Given this list of marker genes Rap1gap, Tap2, Arid5b, Ogfr, Glipr2, Tcf7l2, Mvp, Ube2l6, Bcl2a1d, Ly6e, Psmd3, Eif1, Lap3, Vasp, Ggct, Vps29, Lyar, Mtss1, Dnaja2, Psme2, Tmem38b, Xaf1, Odc1, Cldnd1, Spi1, Rpf2, Mcur1, Hprt1, Fgl2, Tle3, Noc4l, Tbcb, Mrpl21, Sdad1, Lcp2, Srp19, Il10ra, Zbp1, Zfp318, Cd274, Serpina3f, Psma7, Tapbpl, Txndc17, Itgae, Lrrc59, Mat2a, Hhex, Srsf3, Gbp4, Polr2i, Pdha1, Wdr43, Bcl2l14, Marchf5, Ube2l3, Gbp7, Bbx, Snrnp40, Ccl17, Anxa4, Ube2n, Edem1, Ifi207, Sp110, Mdfic, Zyx, Psmb10, Cacnb2, Vdac2, Ly6a, Cnp, Gpr33, Hnrnpab, Irf5, Sting1, Eloc, Rmdn3, Isg15, Lgals3bp, Trafd1, Farsa, Larp1b, Samhd1, Socs2, Pals2, Irgm2, Ikzf2, Laptm4b, Lsm1, Prkd3, Slco3a1, Irf1, Reep3, H2-DMb2, Peli1, Ifi204, Igtp (NCBI Gene Id 16145), Ssr2, Eif6, Calhm6 (calcium homeostasis modulator family member 6), Lims1, Ifi47, Riok3, Nop58, Nufip1, Ccnd2, Cops5, Prdx1, Ndufab1, Procr, Chd7 (chromodomain helicase DNA binding protein 7), Cyrib, Plek, Ppa1, Acer3, Rexo2, Larp1, Ccl22, Ezr, Gbp5, Nmi, Pnp, Nfu1, Pgk1, Ccdc124, Ube2e1, Zc3h7a, Gyg1, Icam1, Orai1, Fcgr4, Irgm1 (immunity-related GTPase family M member 1), Pml, Cish, Cope, Fen1, Ranbp2 (RAN binding protein 2), Lyn, Atp6v1d (ATPase, H+ transporting, lysosomal V1 subunit D), Cflar, Nampt, Rrbp1, Tsg101, Emd, Rp2, Nfkb1, G3bp1, Tuba1a, Dnase1l3, Nme1, Scimp, Traf1, Slamf8, Ranbp1, Cd38, Cltc, Psma3, Snx6, Slc35b1, Rbm26, Ralgds, Ifi35, Nlrc5, Creb3, Rer1 (retention in endoplasmic reticulum sorting receptor 1), Gmppb, B2m, Trim30a, Tes, Prkx, Arf3, Adap2, Hnrnpd, Cd86, Parp9, Slc4a8, Sdc4, Hsp90aa1, Gpd2, Ifi211, Sar1a, Tmbim6, Pgam1, Eif4a1, Coro2a, Tmem131, Wars1, Srsf2, Kynu, Zup1, Ass1, Sav1, Rtf2, Atp5f1b, Smarca5, Naa25 (N(alpha)-acetyltransferase 25, NatB auxiliary subunit), Rnf213, Stxbp3, Rap2a, Stx11, Atp1b3, Ptpn1, Sumo2, Ccdc86, Csf2rb, Mkrn1, Spop, Prmt1 (protein arginine N-methyltransferase 1), Manf, Uso1, Rbms1, Ddx39a, Sbno2, Bcl2a1b, Usp7, Max, Fbxo4, Atp6v1g1, Tapbp, Slc33a1, Ece1, Sh3glb1, Ppp1r11, Malt1, Bcl2a1a (B cell leukemia/lymphoma 2 related protein A1a), Psmd12, Psmb8 (proteasome (prosome, macropain) subunit, beta type 8 (large multifunctional peptidase 7)), Mbd2, Trio, Cst3, Ndrg1, Tspo, Efhd2, Spcs2 (NCBI Gene Id 66624), Ptprc, Psmb9 (NCBI Gene Id 16912), Nfkbie (NCBI Gene Id 18037), Ssu72, Snu13, Kcmf1 (NCBI Gene Id 74287), Ube2d3, Flnb, Hspa4, Pdia6, Tmed5 (NCBI Gene Id 74336), Pim1, Lgals3, Atp6v1a, Tpr, Tent5c, Morf4l1, Gnb4, Cycs, Plgrkt, Parp14, Arl8b, Gadd45b, Kmo, Slfn5, Brix1, Ccnd3, Fh1, Dnaja1, Mthfd2, Sri, Csrp1, Trib1, Ifi205, Itsn2, Smarce1, Slfn2, Ywhae, Nudt9, Fkbp1a, Litaf, Creld2, Napsa, Snap23, H2-D1, Stat2, Cebpb, Pdcd10, Stat1, Prkcd, Xbp1, Pdia3, Serpinb9, Pfn1, Katna1, Nras, Tubb4b, Hspa5, Acadl, Parp12, Ccdc25, Irf8, Ly86, Rap1b (RAS related protein 1b), Ppp4r2, Tuba1b, Basp1, Fam241a, Socs1, Psma4, Ctsz, Clic4, Zcrb1, Ildr1, Csf2rb2, Casp4, Plaat3, Gtpbp4, Rwdd1, Elmo1, Cdkn1a, Nudt4, Ube2s, Serpina3g, Sowahc, Rars1, Irf7, Lsm12, Als2, Tpm4, Dnajb11, Psmb6, Casp8, Usp18, Rab2a, Gbp3, Mab21l3, Txn1, Bst1, Eif5a, Cct8, Nrros, Picalm, Tnf, Eps8, Serpinb6b, Pkib, Ldlr, Rngtt, Galnt7, Slfn1, Clec2d, Cct3, Abhd16a, Eif2s1, Pmepa1, Cacybp (calcyclin binding protein), Tsr1, Eif2s2, Nabp1, Oxct1, Denr, Fnbp1l, Stat3, Tmem131l, Apol7c, Arhgap22, Ncbp3, Ttc39b, H2-K1, Ier3, Tap1, Slc8b1, Gbp9 (NCBI Gene Id 236573), Plaa, Etv6 (ets variant 6), Cmtm6, Pfkp, Ciao2b, Klrk1, Ctsc, Arf6, Mrps7, Stx7, Csnk2b (casein kinase 2, beta polypeptide), Sec63, Calr, Srgn, Cd40, Hk3, Psma2, Mif, Iigp1, Esyt2, Ppp6r1, Myd88, Cxcl9, Gatm, Apol10b, Arf4, Rab7, Trim30d, Ebp, Cd24a, Lncpint, Rasa4, Armc8, Gbp2, Oat, here is a description of the gene set: from publication Cui A, Huang T, Li S, Ma A, Pérez JL, Sander C, Keskin DB, Wu CJ, Fraenkel E, Hacohen N (PMID 38057668) species: Mus musculus Mouse Gene Set: CUI_CDC1_IL18_RESPONSE_UP Genes positively differentially expressed in cell type: cDC1 (conventional dendritic cell type 1) upon treatment with cytokine: IL-18 in mouse lymph nodes in vivo. Cytokines mediate cell-cell communication in the immune system and represent important therapeutic targets. A myriad of studies have highlighted their central role in immune function, yet we lack a global view of the cellular responses of each immune cell type to each cytokine. To address this gap, the authors created the Immune Dictionary, a compendium of single-cell transcriptomic profiles of more than 17 immune cell types in response to each of 86 cytokines (>1,400 cytokine-cell type combinations) in mouse lymph nodes in vivo. A cytokine-centric view of the dictionary revealed that most cytokines induce highly cell-type-specific responses. For example, the inflammatory cytokine interleukin-1β induces distinct gene programmes in almost every cell type. A cell-type-centric view of the dictionary identified more than 66 cytokine-driven cellular polarization states across immune cell types, including previously uncharacterized states such as an interleukin-18-induced polyfunctional natural killer cell state.